The following is a description of a gene set: TREM-1 is an orphan immunoreceptor expressed on monocytes, macrophages, and neutrophils. TREM-1 associates with and signals via the adapter protein DAP12/TYROBP, which contains an immunoreceptor tyrosine-based activation motif (ITAM). TREM-1 activation by receptor cross-linking is pro-inflammatory, and can amplify cellular responses to Toll-like receptor (TLR) ligands such as bacterial lipopolysaccharide (LPS). To investigate the cellular consequences of TREM-1 activation, we have characterized global gene expression changes in human monocytes in response to TREM-1 cross-linking in comparison to and combined with LPS. Both TREM-1 activation and LPS up-regulate chemokines, cytokines, matrix metalloproteases, and PTGS/COX2, consistent with a core inflammatory response. However, other immunomodulatory factors are selectively induced, including SPP1 and CSF1 (i.e., M-CSF) by TREM-1 activation and IL-23 and CSF3 (i.e., G-CSF) by LPS. Additionally, cross-talk between TREM-1 activation and LPS occurs on multiple levels. While synergy in GM-CSF protein production is reflected in commensurate mRNA abundance, comparable synergy in IL-1b protein production is not. TREM-1 activation also attenuates the induction of some LPS target genes, including those that encode IL-12 cytokine family subunits. Whereas positive TREM-1 outputs are abolished by the PI3K inhibitor wortmannin, this attenuation is largely PI3K-independent. These experiments provide a detailed analysis of the cellular consequences of TREM-1 activation, and highlight some of the complexity in signal integration between ITAM- and TLR-mediated signaling. Genes up-regulated in comparison of monocytes treated with 1 ng/ml LPS (TLR4 agonist) versus monocytes treated with anti-TREM1 and 5000 ng/ml LPS (TLR4 agonist). species: Homo sapiens Human Gene Set: GSE9988_LOW_LPS_VS_ANTI_TREM1_AND_LPS_MONOCYTE_UP from publication Dower K, Ellis DK, Saraf K, Jelinsky SA, Lin LL (PMID 18292579), and this is the list of marker genes: IPPK, TNIP3, IL12B, TRADD, AP1B1, PTAFR, EZH2, CT75, KLF7, BCL2L1, SLC1A3, MOGS, UGP2, EPB41L3, DNAJB6, STX11, EFNA1, FAM89B, TOR1B, XRCC5, UBE2W, NECTIN2, ARID1A, ADA, CNN2, MRPS24, CCL1, FNBP1, ITGB8, IL10RA (NCBI Gene Id 3587), GTF3C6, HNRNPR, PLAC8, EYA3, CDC42EP2, RHOG, ARRB1, MAP3K8, STK38, IER5, GNB2, ZNF217, ANP32A, PSEN1, GAL3ST4, RBM22, IL4I1, RUBCNL, FJX1, CYBB, SPACA6, SMG9, STK17B, TGFBR2, VASP, ATP6AP1, SLC30A7, QKI, TBC1D10A, KCNJ2-AS1, ACVR2A, EBI3, NIN, ACOD1, KCNJ2, NFE2L2, GPR107, CMKLR1, FBH1, PNRC1, CCL23, TP53INP1, LYSMD2, ATXN7L1, RSPH6A, TMEM123, FPR3, SERPINB1, TGS1, SRSF11, SIRPA, RND1, SINHCAF, CCDC71L, LACC1, SYNPO2, GRAMD1A, NLRP3, PARP10, KCNA3, IKBKE, LAIR1, FPR2, RASSF5, PFKFB3, TNFAIP2, BCL9L, IL20, TLR8, ADH1B, ANO5, IL23A, STAT5A, KCNK15-AS1 (KCNK15 and WISP2 antisense RNA 1), NBR1, CCSER2, EPM2AIP1, GCH1, SGPL1, BIRC3, IRF1, DCP2, TNFRSF10B, ACSL1, NFKBIZ, LINC01138, VAV1, OSR2, TLR4, CSF3, NCOA4, ARHGAP31, PDE4B, CXCL1, GNG2, CTNND1, SIX5, LRRC8D, CNTLN, HAS1, PLEKHF2, FBXO42, DNAJA1, THBS1, MYD88, RHOU, MIR3945HG, CMTM6, HDGF (heparin binding growth factor), CEP135, PSMA6, OASL (2'-5'-oligoadenylate synthetase like), CREBL2, GRB2, SAMSN1, FSCN1, RIN2, TNIP1, N4BP1, FFAR2, TNFRSF9, TIFA, PLXNC1, PTPRJ, SERP1, SLA, TAOK3, RNF19B, CHST2, TNFAIP3, MCOLN2, KDM1A, NDUFAF6, RAP2C, MTF1, LILRB2, CLIC4, SLC2A6, TAB2, GPR132, MXD1, ZC3HAV1, RELA, ANKRD33B, ZNF436, PIK3R5 (NCBI Gene Id 23533), CLEC4E, EHD1, SMCO4, TMTC2, OAZ2, MARCKSL1, ENG, DCUN1D3, PSTPIP2, CYRIA (CYFIP related Rac1 interactor A), MIR9-1HG, TRIP10, HCAR3, BID, RNF144B, GAPT, ACKR3, PIK3AP1, GRINA, ENTR1